The following is a description of a gene set: Any process which modulates the frequency, rate or extent of cAMP-mediated signaling. studied in species Mus musculus Mouse Gene Set: GOBP_REGULATION_OF_CAMP_MEDIATED_SIGNALING, and this is the list of marker genes: Sctr, Crhr2 (NCBI Gene Id 12922), Pde10a, Gnai1, Adcyap1, Aplnr, Gipr, Chga, Cdc34, Pex5l, Adcyap1r1, Taar1, Lpar1, Sct, Pde11a, Cdc34b, Rasd2, Adora2b, Oprm1, Rxfp2, Crhr1, Mgrn1, Pde4d, Pde3b, Ptger3, Ucn, Nucb2, Ghrh, Ube2b, Oprl1, Gip, Insl3, Npy2r, Ptger4, Pde3a, Pebp1 (NCBI Gene Id 23980), Gpr3, Pde2a, Crh, Ece1